The following is a description of a gene set: Cluster 1: genes up-regulated in lung tissue samples from mice with oncogenic form of KRAS and inactivated PTEN. species: Mus musculus Phosphatase and tensin homologue deleted from chromosome 10 (Pten) is expressed aberrantly in non-small cell lung cancer cells, but the role of Pten in lung neoplasia has not been fully elucidated. In this study, we used a genetic approach to inactivate Pten in the bronchial epithelium of mice. Although, by itself, Pten inactivation had no discernible effect on bronchial epithelial histology, it accelerated lung tumorigenesis initiated by oncogenic K-ras, causing more rapid lethality than that induced by oncogenic K-ras alone (8 weeks versus 24 weeks of median duration of survival, respectively). Lung tumors arose in K-ras mutant, Pten-deficient mice that rapidly obstructed bronchial lumina and replaced alveolar spaces. Relative to K-ras mutant tumors, the K-ras mutant, Pten-deficient tumors exhibited more advanced histologic severity and more prominent inflammation and vascularity. Thus, Pten inactivation cooperated with oncogenic K-ras in promoting lung tumorigenesis. from publication Iwanaga K, Yang Y, Raso MG, Ma L, Hanna AE, Thilaganathan N, Moghaddam S, Evans CM, Li H, Cai WW, Sato M, Minna JD, Wu H, Creighton CJ, Demayo FJ, Wistuba II, Kurie JM (PMID 18281487) Human Gene Set: IWANAGA_CARCINOGENESIS_BY_KRAS_PTEN_UP, and this is the list of marker genes: IGBP1, CYLC2, ARG1, MAP6, GPRC5C, PHF10, IFNA1, LAMP2 (NCBI Gene Id 3920), KIAA1671 (KIAA1671), IL36RN, TMEM33, RSL1D1, RNF20, INAVA, SLC17A9, TMEM177, BNIP2, NOL11, ZNF687-AS1, ZMYND11, LDHD, GLA, HSPA1B (heat shock protein family A (Hsp70) member 1B), GABRP, NDUFS6, DTNB, ATP6V1C1 (ATPase H+ transporting V1 subunit C1), SUPT20H, EGLN3, NTF4, LDB1, CP, RAB7A, ZC3H14, RPRD2, TVP23A, RNF128, ADAM19, SERPINF1, ACAP2, BHLHE40, FHIP1B, RAMP1, GTF3C4, TRIM71, UBA2, WNK1, TOP1, CA10, NFATC2, HMOX1, NT5C2, TDRP, MYNN, ENPEP, NCAPD3, GEMIN5, MIA, DMBT1, LMX1A, ISL1, KBTBD12, FREM2, MIS18A, ADAMTS10, MAPK8, LY6D, PDGFC, FOXJ1, BCAP29, NUCB2, HGF, PRG4, TCAF2, RAB39A, LAMB3, ATP6V0A1, ZNF827, OPRL1, MAGEB16, RGS5, RBM26, BMERB1, TMEM107, CCR1, ANKRD55, GOLM1, CR1L, COPG1, GSDMA, TBCA, AKAP10 (A-kinase anchoring protein 10), RPGR, GRIN1, MFSD4A, PGM3, SERPINE1, WWP2, MPZL2, IPO13, POLG, RECQL, PPIC, B3GALNT2, TP63 (tumor protein p63), AXIN2, TCL1B, KNG1, METTL26, CLDN2, PGAP1, FANCL (FA complementation group L), CCL15, GID4, CALHM5, GABRA1, RBM46, ERCC2, COL5A1, CD14, ZNF691, CDHR1, F3, ACOT2, BICDL1, KRTDAP, RET, HSPA2, PLCH2, CALB1, MIF, EIF4EBP2, CHAC2, CTSB, CDC23, KCNK6, ELAVL3 (NCBI Gene Id 84241), FER, ERCC6L, GPR149, PKIB, OGA, SIGLEC1, SFTPA2, HES3, ADAMDEC1, LMNB1, ZNF414 (zinc finger protein 414), HINT3, DPYS, MORC1, XPO4, LITAF, CHL1, TUBA4A, AKIRIN2, SERPINA3, APPL1, SMPDL3B, HIGD1A, EFCAB12, SENP2, CUL4B, ARL8A, KIF2A, RRAGD, SLC5A1, CETN4P, BACE2, NUDT6, NME8, BCHE, PGK1, C3AR1, TEX13B, RBM18, INTS2, HES2, MIB1, GGNBP1, TCF7L2, DCAF12, GMEB1, MYB (NCBI Gene Id 4602), ARIH1, UOX, BZW1, AKAP8, ODC1, NEFM